Given this list of marker genes Trp73, Rcan2, Reln, Ddx17, Lhx1, Cacna2d2, Calb2, Lhx5, here is a description of the gene set: Genes selectively expressed by Cajal-Retzius neurons in embryonic day 14.5 mouse cortex. species: Mus musculus from publication Bedogni F, Hevner RF (PMID 34321999) Mouse Gene Set: HEVNER_CORTEX_CAJAL_RETZIUS_CELLS